Given this list of marker genes Hgf, Crk, Col24a1, Lama4, Itga3, Col11a2, Gab1, Grb2, Col2a1, Itga2, Col5a3, Ptk2, Tns4, here is a description of the gene set: This event has been computationally inferred from an event that has been demonstrated in another species.<p>The inference is based on the homology mapping from PANTHER. Briefly, reactions for which all involved PhysicalEntities (in input, output and catalyst) have a mapped orthologue/paralogue (for complexes at least 75% of components must have a mapping) are inferred to the other species. Reactome Pathway: MET promotes cell motility electronically inferred by orthology from the curated human pathway part of: Signaling by MET species: Mus musculus